The following is a description of a gene set: Mouse Gene Set: GOBP_POSITIVE_REGULATION_OF_OSSIFICATION studied in species Mus musculus Any process that activates or increases the frequency, rate or extent of ossification, the formation of bone or of a bony substance or the conversion of fibrous tissue or of cartilage into bone or a bony substance., and this is the list of marker genes: Vdr, Ccn1, Rxrb, Ptpn11, Sox11, Osr2, Zbtb16, Mia3, Kl, Thrb, Bmpr1a, P2rx7, Isg15, Smad3, Runx2, Ltf, Ano6, Actn3, Adcy10, Pkdcc, Ptger4, Adgrv1, Wnt4, Alox5, Asxl2, Tfap2a, Ccn3, Cd276, Csf1r, Acvr2a, Fgfr3, Atp2b1 (ATPase, Ca++ transporting, plasma membrane 1), Acvr2b, Fam20c, Tacr1, Tmem119, Tent5a (NCBI Gene Id 320335), Wnt10b, Pth, Bmpr2, Nipbl, Mef2c, Slc8a1, Bmp6, Cnmd, Ptn, Slc20a2, Adrb2, Wnt5a, Fbn2, Bmp4, Scube2, Oxt, Setd2, Fzd9, Acvr1, Gpm6b, Bmpr1b, Atraid, Lrp6, Bmp7, Tob2, Osr1, Tac1, Rxra, Bmp2, Nell1